The following is a description of a gene set: Human Gene Set: GOBP_ENERGY_DERIVATION_BY_OXIDATION_OF_ORGANIC_COMPOUNDS The chemical reactions and pathways by which a cell derives energy from organic compounds; results in the oxidation of the compounds from which energy is released. studied in species Homo sapiens, and this is the list of marker genes: NDUFV2, MT-CYB, CCNB1, FXN, ATG12, PID1, SDHC, CS, RHOA, IDH3A, UQCC3 (NCBI Gene Id 790955), WIPI1, ATP5F1B, PUM2, ABCD1, NDUFV3, ATP5MG, PYGL, SOD2, PDHB, CBFA2T3, PPP1R3D, ETFA, FH, NDUFS3, GNMT, PPP1R3E, UQCC2 (NCBI Gene Id 84300), SUCLG2, SLC25A33, ATP7A, NDUFA4, COQ9, NOP53, PCDH12, BID, COX6C, AGL, COX8C, NDUFC2-KCTD14, IFNLR1, NDUFA11, ACTN3, NHLRC1, PYGB, PPARGC1A, DNAJC15, SELENON, OXA1L, CYC1, CAT, PRDM16, TP53, NDUFS5, GCGR, KHK, PDHA2, COX4I2, SDHA, PPP1CB, PIK3CA, MIR1271, OAS1, COX7A2, SNCA, ACADM, STOML2, TREX1, UQCR11, ADCY10, DGUOK, ACO1, GABARAPL1, DNAJC30, NDUFA13, SDHAF2, NDUFS4, ATP5F1E, ATP5F1EP2 (NCBI Gene Id 432369), RB1CC1, VPS54, MRAP2, MT-CO1, MDH1 (NCBI Gene Id 4190), CHCHD5, ATP5IF1, ATP5PF, C2orf69, CSKMT, PRKAG3, TRPV4, AIFM2, SELENOS, PPP1CC, NDUFA6, ADRB3, COQ10A, PDHA1, PPP1R3F, COX7B, MT-ND2, SUCLG1, GYS1, AK4, IDH2, COX6A2, MT-ND3, ATP5PB, LYRM7, MACROH2A1, GYS2, COX7B2, NDUFA1, MTFR2, INSR, COX7A2L, NDUFS2, MIR195, NDUFB8, DLST, NDUFA8, MLXIPL, MT-CO2, DLAT, ATG2B, CAVIN3 (caveolae associated protein 3), NDUFS7, IRS1, UQCRHL, UQCRC2, ACSM1, MT-ATP6, BCL2L13, NDUFAB1, NDP, UQCRQ, PPP1R3G, EVA1A, PASK, PHKG2, PPP1R1A, COX10, MFN2, COX8A, COX4I1, ADGRF5, ATG2A, ATP5PO, MDH2, KL, IGF1, PTH, UQCRB, PINK1, UQCRFS1P1, PHKA1, NR1D1, OGDHL (NCBI Gene Id 55753), ADHFE1 (alcohol dehydrogenase iron containing 1), SCO2, PRELID1 (NCBI Gene Id 27166, PRELI domain containing 1), IMMP2L, NDUFB1, GCK, COQ10B, WDR45B, ETFB, NDUFB6, LEPR, COA6, ATP5MF, COX7A2P2, SHMT2, KGD4, NFATC4 (NCBI Gene Id 4776), SLC25A51, DYRK2, COL6A1, PLEC, ME3, DLD, MIR15B, NDUFA3, ATP5PD, INPP5K, STBD1, NDUFA9, NDUFC2, UCN, PPP1R2P1, PER2, IL4, EPM2A, NDUFB5 (NADH:ubiquinone oxidoreductase subunit B5), SLC25A23, MT-CO3, NOS2, ANTKMT, CYCS, ATP5F1D, MT-ND4L, PGM2, CYP1A2, ENPP1, SLC25A25, IL10RB, GBE1, MTLN, PHLDA2, ARL2, WIPI2, COX7C, MLDHR, PYGM, COX6A1, CDK1, HCCS, NDUFB11, NDUFB3, COX5B, GFPT1 (NCBI Gene Id 2673), MTOR, EPM2AIP1, IGF2, NUPR1, MYBBP1A (MYB binding protein 1a), PPP1R3B, NDUFA2, SORBS1, ATPSCKMT, MT3, SLC25A13, NDUFA7, SDHD, MSH2, UQCRC1, PRLH, NDUFB2, NNT, COX6B1, NR4A3, NDUFA12, UQCR10, ATG3, GYG2, ACADVL, ADSL, NDUFAF1, SDHB, GAA, PPP1CA, IFNAR1, ATP5ME, PPP1R2B, TEFM, PANK2, TMEM135, G6PC1, BLOC1S1, MTCH2, GFPT2, PHKA2, MT-ND4, AKT1, IDH3B, ENSG00000293600, NDUFC1, PRKAG2, GYG1, PPP1R3A, ATP5F1A, IDH3G, MT-ND6, PPIF, PNPT1, AKT2, UQCRFS1, POMC, COX5A, PPP1R3C, MTCO2P12, MIR210, INS, NDUFB7, PHKG1, GBA1, GSK3B, MFSD8, SUCLA2, HMGB1, SLC25A14, ETFDH, ACO2, OPN3, NIPSNAP2, IDH1, LDHA, WDR45 (WD repeat domain 45), PPP1R2, ABCC9 (NCBI Gene Id 102724274), IFNG, NDUFA5, NDUFS8, MT-ND1, PARK7, TRAP1, IDE, CISD1, PFKM, NDUFB10, NDUFA10, PHKB, CHCHD2, COX6B2, ETFRF1, STK40, SURF1, NDUFB9, IRS2, TIGAR, ADGRF1, NDUFS6 (NCBI Gene Id 4726), OGDH, NDUFB4, MT-ND5, CHCHD10, COMT, GHITM, MTFR1, MTFR1L, SDHAF4, VCP, ATP5F1C, UQCRH, LEP, ISCU, GSK3A, NDUFV1, IL6ST, NDUFS1, MT-ATP8, MDH1B, TNF, RUBCNL, UGP2 (UDP-glucose pyrophosphorylase 2), SIRT3, GRB10, COX7A1